Given this list of marker genes Irf9, Ifna15, Ifna4, Socs1, Ifna9, Ifnar1 (NCBI Gene Id 15975), Ptpn1, Tyk2, Ifna1, Ifna16, Ifna13, Ubb, Socs3, Ifna14, Rps27a, Ifnb1, Kpnb1, Ifna12, Ptpn6, Ifnab, Kpna1, here is a description of the gene set: Reactome Pathway: Interferon alpha/beta signaling part of: Interferon Signaling electronically inferred by orthology from the curated human pathway species: Mus musculus This event has been computationally inferred from an event that has been demonstrated in another species.<p>The inference is based on the homology mapping from PANTHER. Briefly, reactions for which all involved PhysicalEntities (in input, output and catalyst) have a mapped orthologue/paralogue (for complexes at least 75% of components must have a mapping) are inferred to the other species.